The following is a description of a gene set: from publication Chen Y, Wang X (PMID 31504780) Genes predicted to be targets of miRBase v22 microRNA mmu_miR_106a_3p, mmu_miR_17_3p in miRDB v6.0 with MirTarget v4 prediction scores > 80 (high confidence targets). species: Mus musculus Mouse Gene Set: MIR_106A_3P_MIR_17_3P, and this is the list of marker genes: Phf3, Klhl23, Dpy19l3, Yy2, Msh5, Fam98a, Rab11fip5, Aldh1a1, Syncrip, Tanc2, Laptm5, Srek1, H2-Aa (NCBI Gene Id 406213), Mindy4, Usp46, Vezf1, Hdac3, Rasal2 (RAS protein activator like 2), Rreb1, Dclk1 (NCBI Gene Id 99719), Clasp2, Zfp516, Sort1, Acod1, Stat1, Slc7a15, Asap2, Prrc2c, Aebp2, Rmnd5a, Gtf2h1 (NCBI Gene Id 97364), Neurog1, Sirt1, Bcorl1, Ccdc150, Pcdh10 (protocadherin 10), Cep43, Egflam, Poldip2, Zfp120 (NCBI Gene Id 320490), Cep72, Rit1, Rhot1, Cnot4, Ap2a2, Cnot2, Zfp704, Recql4, Wsb1, Zfp619, Mbnl1, Adam7, Zfp799, Rab35, Kif3b, Dhx58, Sorcs2, Btbd10, Fam168b, Sufu (NCBI Gene Id 72652), Bcl2l11, Lin7c (lin-7 homolog C, crumbs cell polarity complex component), Abhd17c, Rab6a, Heyl, Tnrc6b, Adamts15, Col25a1, Ppp4r3a, Grm5, Hspb7, Cdk17, Kcna1 (NCBI Gene Id 17205), Mef2a, Cdin1, Rdh1, Rap2a, Plch1, Doc2b, Brwd3, Col12a1, Ttc4, AW146154, Rab30, Pan3, Nfib, Zfp696, Fgf1, Anapc7, Ebf1, Atg10, Otud7b, Slc40a1, Ttll12, Jmy, Kif5c, Ergic2, Glud1, Hacd2, Eloc, Ctbp2, Gypc, Ppp6r1, Nme3, Csrp2, Usp32